Given this list of marker genes CBL, EGF, STAT3 (NCBI Gene Id 6774), WASL (NCBI Gene Id 8976), DRD2, SLC11A1, LMAN2, APELA, PTPRC, ARRB2, CCL21, CD47, SFRP4, CD300LF, MERTK, B2M (NCBI Gene Id 567), CYBA, CALY (NCBI Gene Id 50632), SFTPD, MBL2, DGKD, AP2B1, ABCA7, FCGR2C, ABCA13, SIRPA, IL2RG, MIR183, APLNR, FCN3, CCR7, MYO18A, CD36, FCGR2A, CDC42, GH1, ANGPT1, HFE, VTN, CLU, PTPRJ, IL15RA, COLEC11, GATA2, AHI1 (NCBI Gene Id 54806), RAP1A (RAP1A, member of RAS oncogene family), APP, CFP, PPT1, FCER1G, NEDD4L, APPL1, PRKACA, C2, AHSG, NLGN1, SERPINE1, PYCARD, ITSN1, TF, RAB27A, NTF3, LRP1, CAMK1D, RAB21, FCGR1BP, VPS28 (VPS28 subunit of ESCRT-I), RAB31, PCSK9, SIRPB1, ARAP1, ANO6, IFNG (interferon gamma), TOR1A, GREM1, ANXA2P2, CD14, NCKAP1L, SMPD1, APLN, MAGI2, TULP1, APOA2, MIR17, C3, FCN2, C4A, APOA1, COLEC10, LDLRAP1, TBC1D5, ITGA2, DLL1, PLCG2, ARRB1, IL15, LYAR, WNT3A (NCBI Gene Id 89780), AZU1, TFR2, CD151, APOE, PLA2G5 (NCBI Gene Id 5322), AP2M1, CLEC7A, GAS6, TUB, CCL2, SPACA3, CLIP3, BIN1, AXL, EEF2K, PPP3CC, SELE, H1-1, SGIP1, MIB1, FPR2, TSG101, APPL2, FCGR2B, STAP1 (NCBI Gene Id 26228), ANXA2, DAB2 (NCBI Gene Id 1601), CCL19, SOD1, CBLL1, IL4, BCR, BICD1, FMR1, DTNBP1, APOA5, PTX3 (pentraxin 3), FCN1, SNCA, IL2RB, HIP1, MIR20A, ATAD1, INSR, VEGFA, RAP1GAP, WNT5A, BTK, CAV3, CD63, LRRK2, FCGR1A, HAMP, ANKFY1, F2RL1, CALR, PPP3CA, AP2A1, DOCK2, TREM2, C4B, PICK1, SIRPG, GPC3 (glypican 3), FLOT1, CLN3, SYK, here is a description of the gene set: Human Gene Set: GOBP_POSITIVE_REGULATION_OF_ENDOCYTOSIS studied in species Homo sapiens Any process that activates or increases the frequency, rate or extent of endocytosis.